The following is a description of a gene set: Genes predicted to be targets of miRBase v22 microRNA hsa-miR-185-3p in miRDB v6.0 with MirTarget v4 prediction scores > 80 (high confidence targets). Human Gene Set: MIR185_3P species: Homo sapiens from publication Chen Y, Wang X (PMID 31504780), and this is the list of marker genes: GIPC3, LRCH4, P2RY6, BCAM, AGAP1, SH2B1, STK24, ST3GAL1, SMG5, JCAD, FAM53C, TEAD2, PITPNM2, CACNA1B, UGT1A4 (NCBI Gene Id 54657), MIX23, MTCL2, RABGAP1L, SUV39H1, PLA2G6, INTS3, CTIF, USP21, SCUBE3, ARGFX, TYSND1, CLEC16A, DCAKD, PPP2CA (protein phosphatase 2 catalytic subunit alpha, NCBI Gene Id 5515), ZFP41, NRARP, FSTL3, URM1, HELQ, NR5A1, CHRNA4, GAS7, UGT1A1, ATP6V0A4, CDH4, HSPA12B, NFE2L1, SPACDR, PKNOX2, UGT1A8, PMEPA1, UGT1A7, SPRN, SERF2, CACFD1, C1QTNF1, IGF2BP1, FIS1, ARHGAP1, VAV2, LRP1, ESPN, PAK1, UGT1A9, TOM1L2, CPLX2, CASQ1, CAMTA1, PAN3, SLC10A3, ABHD4, ELMO1, SLC30A3, ILRUN, PAX9, PRAF2, LRRC32 (leucine rich repeat containing 32), MADD, DNM1, GALNT16, SOX4, PRKCA, CD74, PAX5, GNAI2, SLC45A3 (NCBI Gene Id 85414), CLDN19, N4BP3, FIGN, SCML4, APC2, SLC46A1, BAP1, SMG7, PLXNA1 (NCBI Gene Id 84202), UGT1A5, SLC6A8, RGS6, UGT1A3, KIF21B, PML, DPYSL5, EVC2, UGT1A6, TTYH3, ASIC4, FAM163A, POLA2 (NCBI Gene Id 23649), MECP2, FSTL4, TMEM105, MFGE8, MVB12B, PEX10, GNAT1, EPHA8, PHF19, ZCCHC24, BOK, PPARD, ARK2C, SBF1, FBXO41, ARC, TSPAN5, ZNF544, FEV, CABP7, KLK4, PAK4, MAP6, ZDHHC3, PEX14, GEMIN8, WDTC1 (NCBI Gene Id 23038), PDAP1, SH3PXD2A, COPS7B, IP6K2, GNG13, INSYN1, UGT1A10, ADARB2, FBXL16, SOX10, TSPAN11, MAPKBP1, KCNJ12, ACAP3 (ArfGAP with coiled-coil, ankyrin repeat and PH domains 3), HIVEP3, NTNG1, PLEKHM3, DCLK3 (doublecortin like kinase 3), VPS37C, TRIM29, MAMLD1, SLC7A1